Given this list of marker genes Ext1, Vegfa, Ctnnb1, Hs3st3a1, Sox2, Pax8, Wnt1, Gbx2, Agtr2, Agtr1b, Shh, Flt1, Notch1, Eya1, Kdr, Lama1, Stk4, Six1, Ctsl, Bcl2, Pbx1, Spry1, Agtr1a, Bmp2, Med1, Pkhd1, Pspn, Yap1, Nrp1, Tacstd2, Hhex, Esrp2, Lrp5, Msx2, Foxa2, Gli3, Adamts16, Ahr, Pax2, Plxnd1, Hoxa11 (NCBI Gene Id 15396), Ppp3r1, Tcf21, Pkd1, Ednra, Etv5, Tbx1, Foxc2, Vdr, Srf, Sirt6, Col4a1, Nfatc4, Tmem67, Tfap2c, Lrp6, Ilk, Notch4, Rdh10, Tbx2, Dag1, Areg, Cited1, Tmem59l, Fgfr2, Sall1 (spalt like transcription factor 1), Clic4, Wnt6 (NCBI Gene Id 98195), Mks1, Ihh, Nkx2-1, Npnt, Bmp7, Fgf1, Lhx1, Nog, Smo, Six4, Sema5a, Lgr4, Angpt1, Sema3e, Fgf8, Tnc, Src, Cav3, Ctsz, Epha2, Ctsh, Mgp (matrix Gla protein), Tmtc3, Maged1, Pak1, Phb2, Slc12a2, Fat4, Ctsd, Lef1, Igf1, Edn1, Csmd1, Rasip1, Kdm5b, Gli2, Foxf1, Pdgfra, Hs3st3b1, Gdnf, Dchs1, Ddr1, Fkbpl, Cxcl12, Tgfbr2, Gdf7, Nrarp, Wnt9b, Tek, Mdk (NCBI Gene Id 17242), Met, Eng, Smad4, Sfrp2, Nfatc1, Tgfb1, Nkx3-1, Cxcr4, Cited2, Foxa1, Gdf2, Pgr, Wnt5a, Foxd1, Tnf, Pxn, Fgf2, Spry2, Lama5, Casr, Tbx20, Mycn, Greb1l (growth regulation by estrogen in breast cancer-like), Sox8, Ar, Gzf1, Pgf, Esr1, Csf1, Etv4, Hoxb7, Esrp1, Wt1 (NCBI Gene Id 319408), Dicer1, Ccl11, Slit2, Mmp14, Gpc3, Tbx3, Hhip, Wnt2b, Rspo2, Dll4, Sox9, Gna13, Celsr1, Dlg1, Pkd2, Cd44, Wnt4, Rbm15, Ppp1ca, Hmga2, Dspp, Btrc, Egf, Ptch1, Grem1, Wnt2, Hnf1b, Kras, Hoxd11, Bmp4, Pitx2, Six2, Dlg5, Nfatc3, Acvr1, Myc, Agt, Ncoa3, Ctnnbip1, Pml, Vangl2, Abl1, Timeless, Fgf10, Hoxa5, Tie1, here is a description of the gene set: species: Mus musculus Mouse Gene Set: GOBP_BRANCHING_MORPHOGENESIS_OF_AN_EPITHELIAL_TUBE The process in which the anatomical structures of branches in an epithelial tube are generated and organized. A tube is a long hollow cylinder.